The following is a description of a gene set: studied in species Mus musculus Any process that stops, prevents, or reduces the frequency, rate or extent of the regulated release of dopamine. Mouse Gene Set: GOBP_NEGATIVE_REGULATION_OF_DOPAMINE_SECRETION, and this is the list of marker genes: Abat, Cnr1, Entpd1, Myo5a, Drd2, Syt11, Gabbr1